The following is a description of a gene set: Human Gene Set: GOMF_OXIDOREDUCTASE_ACTIVITY_ACTING_ON_THE_ALDEHYDE_OR_OXO_GROUP_OF_DONORS_DISULFIDE_AS_ACCEPTOR species: Homo sapiens Catalysis of an oxidation-reduction (redox) reaction in which an aldehyde or ketone (oxo) group acts as a hydrogen or electron donor and reduces a disulfide., and this is the list of marker genes: OGDH, BCKDHA, DHTKD1, PDHA2, PDHA1, OGDHL, BCKDHB, PDHB